Given this list of marker genes Nop9, Fcf1, Tbl3, Tsr1, Bop1, Rcl1, Rpp40 (NCBI Gene Id 24016), Rrs1, Rps21, Npm1, Utp23, Bms1, Nol9, Sde2, Abt1, Kri1, here is a description of the gene set: Mouse Gene Set: GOBP_ENDONUCLEOLYTIC_CLEAVAGE_OF_TRICISTRONIC_RRNA_TRANSCRIPT_SSU_RRNA_5_8S_RRNA_LSU_RRNA Endonucleolytic cleavage of a pre-rRNA molecule originally produced as a tricistronic rRNA transcript that contains the Small SubUnit (SSU) rRNA, the 5.8S rRNA, and the Large SubUnit (LSU) rRNA, in that order, from 5' to 3' along the primary transcript. Primary ribosomal RNA transcripts with three genes, in this order, are produced in the nuclei of many eukaryotic species, including S. cerevisiae. species: Mus musculus